Given this list of marker genes Enpp7, Naga, Prkcd, Smpd2, Hexa, Neu4, Sgpl1, Asah2, Lct, Acer2, Asah1, Vps54, Etnppl, Smpd3, Gba2, Smpd1, Psap, Neu2, Neu3, Gm2a, Smpdl3a (NCBI Gene Id 70336), Glb1, Zpbp2, Cyp1b1, Gba1, Smpd5, Acer1, Acer3, Pnliprp2, Flvcr2, Cel, Smpd4, Gla, Neu1, Smpdl3b, Enpp2, Galc, Hexb, Mgst2, here is a description of the gene set: Mouse Gene Set: GOBP_MEMBRANE_LIPID_CATABOLIC_PROCESS studied in species Mus musculus The chemical reactions and pathways resulting in the breakdown of membrane lipids, any lipid found in or associated with a biological membrane.